The following is a description of a gene set: Any process that stops, prevents, or reduces the frequency, rate or extent of cell-cell adhesion mediated by cadherin. studied in species Mus musculus Mouse Gene Set: GOBP_NEGATIVE_REGULATION_OF_CELL_CELL_ADHESION_MEDIATED_BY_CADHERIN, and this is the list of marker genes: Bmp6, Vegfa, Tgfb1, Rgcc, Notch4, Epcam, Mad2l2, Notch1, Nexmif, Ppm1f